Given this list of marker genes CSNK2A1, PARD6G, POLR1B, SPSB1, TAF11L13, WDR26, ANAPC2, CCNT2, LAS1L, KLHDC1, NFS1, ZC3H13, SPOP, POTEE, BARD1, TCEA1, CUL7, FEM1B, POLD1, POLR2L, ERCC8, PHF1, PKLR, TRIM21, ACVR2A, PFKP, ZZZ3, BABAM2, PRAMEF25, GTF2H3 (general transcription factor IIH subunit 3), ASB9, CDK5, ZYG11B, MED10, OSGEP, DPM2, TBP, POLR2J3, ASB1 (ankyrin repeat and SOCS box containing 1), CUL2, SPSB3, RCHY1, THUMPD3, RNF144B, RBM15B, HDAC9, WDR5, POLR1D, WDR4, TAF2, TBKBP1, ANAPC7, PAXIP1, UBE4A, SOCS7, CCNB3, ACACB, KDM6B, SKP1, UBE2J2, POLR2K, BCCIP, RABGGTB, KBTBD7, SNRPF, ZSWIM8, TBK1, RICTOR (RPTOR independent companion of MTOR complex 2), OST4 (oligosaccharyltransferase complex subunit 4, non-catalytic, NCBI Gene Id 100128731), NAA25, ATG13, UTY, PAGR1, EP300, HADHB, POLR2H, RPAP1, POLR2G, KBTBD8, FEM1A, TNFAIP1, SNRPE, CCNE1, FBXL17, TRIM37 (NCBI Gene Id 4591), BRPF1, CDC23, SUGT1, POLD3, NAA50, CHD8, BECN1, OTULIN, PHKG2, NRBF2, SUPT20HL1, TBC1D5, HCFC2, BRD1, PRKAR1B, ENY2, PRIM1, KCTD2, FBXO39, MED21, JARID2, MED8, MKLN1, POTEJ, JADE3, UBAC1, FBXL4, ZDHHC9, IFIT5, SHARPIN, POLD4, CDK10, ACTB, ANAPC13, FBXW5, GAN, DCAF12L1, KLHL8, GON7, ATF2, WWP2, TP53RK, PHKG1, FBXO46, BTRC, PARD6B, ACVR1C, MED13, FBXO2 (F-box protein 2), KBTBD6, MAT2B, KLHL12, MAD2L2, CDK4, MEAF6, KLHL11, CAB39L, FBXO3, UBE2C, VAC14 (VAC14 component of PIKFYVE complex), POLR2M, DTL, KLHL23, PRDM4, CLNS1A, METTL4, DMAC2, ANAPC10, POLR1F, BRD8, GTF2E1, TUFT1, POLE2, LYRM4, NCCRP1 (NCCRP1, F-box associated domain containing), RPN2, FNTB, PIGY, DCAF6, PEX2, DBF4, TAF5, CDK2, ANAPC4, PRAMEF26, POLR2F (NCBI Gene Id 5435), TERC, ASB12, LRRC75A, FZR1, UGT3A2, STK11, KDM6A, PIGS, TRPC4AP, BRCA1, N6AMT1, XRCC6, STT3B, PIAS4, RUVBL2, CKS1B, FBXO10, ABAT, TREX1, UBE2V1, WDFY3, PRKN, CCNY, PRAMEF6, POLR2E, FBXW4, TAF11L14, CCNA1, ZSWIM4, CDK19, DCAF8L2, TAF11L9, DLD, KLHL6, IPP, SNRPD2, ACVR2B, DCAF10, KLHL40, STRADB, RNF14, MCM3, KAT14 (lysine acetyltransferase 14), SF3B3, KDM1A, STRADA, PRKAR2A, POLR1C, PRAMEF7, NSMCE4A, PRKAB2, TAF11L2, PDCD6, ERN1, MED6, ANAPC15, GOLGA7, FBXO11, FBXL5, MAEA, YEATS2, PRAMEF5, SUPT7L, POLR2J2 (RNA polymerase II subunit J2), UBE2B, TAF13, RANGAP1, ING4, POLE3, KAT2A, DCUN1D2, MSL1, AKAP14, CCNT1, KLHL10, PAF1, RIOK1, NAA11, RTF1, TRRAP, RB1CC1, SYVN1, CDK7, GOLGA7B, CDK5R2, GTF2E2, ANAPC11, PRKY, FBXL20, VIRMA, PSG9, CCNL1, NAA10, MOCS2, PAAF1, FXN, AMN1 (NCBI Gene Id 196394), TAF9B, SAMD11, KCTD13 (NCBI Gene Id 253980), PIGU (NCBI Gene Id 128869), DCAF15, TMEM258, PRIM2, NAA20, CBLL1, DAD1, GTF2H2, CCNJL, CRCP, MNAT1, MAT2A, BOD1L1 (NCBI Gene Id 57219), KLHL25, SUPT20H, RMND5B, CCIN, TAF11L11, USP33, DDB2, GMPPA, GTF2F2, PRAMEF33, PDSS1 (NCBI Gene Id 23590), MED1, FBXL2, FBXO9, TAF6, IKBKE, ELOB, KANSL2, PRAME, RNF19B, PRAMEF17, RANBP9, FUT6, PRPF31, FBXL15, RCOR1, STUB1, ORMDL1, DNMT3L, KLHL20, PDSS2, MED17, ATG101, PIK3R6, ZER1, DCAF12, PFKFB1, PRKAA2, KAT6B, F13B, TADA1, PRPS1L1, KMT2D, TAF3, KLHL22, KAT8, TANK (TRAF family member associated NFKB activator), MEN1, TAF11L6, RNF8, FBXO38, CDK3, FBXW7 (NCBI Gene Id 55294), GTF2A1, FBXL16, PRAMEF2, CTR9, CDC27 (cell division cycle 27), POLD2, IKBKB, RPTOR, ANKRD9, KLHL41, PRAMEF18, MSL3, GMPPB, PCGF6, ANAPC1, PIK3CA, COMMD1, GTPBP3, ARMC5, CDK11B, POLR3H, GTF2A1L, PIGC, MBTD1, PIK3R5, TRMT11, FBXW8, ULK1, FBXL12, CCNQ, GNPTG, ALG14, MORF4L1, PHKA1, POLR3GL, SPTLC2, PCGF1, TBPL1, TADA2A, FNTA, ASB11, SESN2, GID8, CCNK, PIGP, QTRT1, TRAF2, PRAMEF8, JADE1, UBE3D, TGFBR1, DPH1, PIK3CD, PRKAR2B, STT3A, CHRAC1, POLR1E, RNF144A, PIK3R3, PCGF3, PRKAR1A, KAT2B, NAA16, USP22, EID3, NCOA6, UBXN8 (NCBI Gene Id 7993), TRAF7, GTF2F1, GTF2B, SNW1, SPTSSA, POLR3B, PRIMPOL, FBXW11, BUB1B, MMS19 (NCBI Gene Id 64210), CKS2, POLR1H, POLRMT, MBIP, PCMTD1, SENP3, FBXL3, TAF10, ARMC8, FBH1, ANAPC5, CDK13, THG1L (tRNA-histidine guanylyltransferase 1 like), SPSB2, SUZ12, YPEL5, POLR3K, DHDDS, TUSC3, DYDC1, WTAP, DCAF12L2, BECN2, UBE2U, CDK16, UBE2V2, ING3 (inhibitor of growth family member 3), COP1, POLR3A, ACTL8, PRAMEF12, TRMT61B, ARIH1, CBX6, SPTLC1, KBTBD3, KANSL1L, KLHL5, DPY30, PRKAB1 (NCBI Gene Id 5564), PIGH, GTF2H2C_2, PHC1, PHF19, MCRS1, ATXN7, MED27, SETD1B, ING5, DAW1 (dynein assembly factor with WD repeats 1), FBXO21, RNMT, CCNH, ATG5, UGT3A1, BRPF3, RNF2, CTU1, C9orf72, KLHL38, MAGT1, SNRPB (NCBI Gene Id 6628), ARIH2, MARCHF6, CDC20, PRAMEF22, DCUN1D4, HSD17B10, PEF1, ERCC3, MSL2 (NCBI Gene Id 55167), SAMD7, PHKB (phosphorylase kinase regulatory subunit beta), POMT1, PRAMEF15 (PRAME family member 15), GTF2H5, POTEI, RAMAC, POLE4, RBCK1, RNF168, CDC26, TRAF3, TMEM183A, MYZAP, CBX8, CBX5, DAPK1, CUL4B, DBF4B, DDB1, PRAMEF19, CDK14, PCGF5, ABTB1, LEO1 (NCBI Gene Id 123169), POLR2A, KANSL1, ZSWIM5, PIK3CB, PIGQ (phosphatidylinositol glycan anchor biosynthesis class Q), MORF4L2, UBR2, SEL1L (SEL1L adaptor subunit of SYVN1 ubiquitin ligase), AZI2, USP47, PCNA, PHF20L1, REV3L (NCBI Gene Id 7807), HSD17B12, TRMT6, KLHL9, WDR5B, TAF9, PRKAG2, FBXO7 (F-box protein 7), BRCA2, ASB4, TAF4, PARD6A, KBTBD2, NSMCE1, EP400, FBXO31, UBE2N, SKIC8, SGF29, TENT2, CCND2, EED, TAF4B, FBXO4, RNF31, CUL4A, EZH2, OGT, KLHL21, PRAMEF20, SMC5, ELOC, ZYG11A (NCBI Gene Id 440590), MTOR, KLHDC3, PFKM, DCAF17, POTEKP, PCGF2, PRAMEF11, IGF1R, POLR2I, GID4, KLHL18, NUS1, AEBP2 (AE binding protein 2), FBXO32 (F-box protein 32), SMURF2, F13A1, THUMPD2, TAF6L, PRAMEF1, EPC2, PIGT, FBXL19, RBX1, KLHDC2, WDR82, FBXL14, POTEF, YEATS4, SNRPD3, SUPT20HL2, ACTL6A, RNF217, MGRN1, DEPDC5 (DEP domain containing 5, GATOR1 subcomplex subunit), PFKL, DPH2, FBXO48, TAF8, WDR38, TRMT112 (tRNA methyltransferase activator subunit 11-2), INO80C, HADHA, PRAMEF4, UBE2L3, CSNK2A3, CAB39, ASH2L, DCAF4, MGA, ERC1, TEX10, TAF11L10, PRAMEF10, PIGA, DET1, CUL5, ENC1, DDOST, KCTD10, RNF11, POLR3G, CDC73, ACTBL2, ATG14, TAF11L7, DCAF4L2, RBBP5, ZNF335, HCFC1, UBE4B, DDA1, FBXL13 (NCBI Gene Id 222235), CUL9, CCNE2, WDTC1, MEGF8, CDKN2D, IRS1, KLHDC10 (NCBI Gene Id 23008), PYDC1, ELOVL6, PRKCI, ATG12, KCTD5, MAT1A, GPR37, E2F6, TAF1, DCAF7, RB1, AMBRA1, UBR1, KLHL35, RANBP10, CDK6, PIGM, POLG, KLHL30, GLMN, TAF1L, TAF11L4, UBR3, RNF40, DCAF8, KLHL17, FBXO42, CCNG2, CDK9, RNF7, VPS72, TAF7, ALG13, FBXL6, PRKACA, EZH1, MAVS, PIK3R4, SNRPD1, TAF7L, TAF11L3, KEAP1, MSL3B, PRKAA1, MAP3K7, QTRT2, GTF2H4, SKP2, ATG16L2, FBXO6, IKBKG, CCND1, AMFR, OSTC, CHUK, TAF11L8, CCNA2, PRKACB, POLR2J, DCAF1, CBX2, PHKA2, CCNP, PARD3, MAP3K5, CCNB1, CCNI (NCBI Gene Id 10983), KCTD17, CCNG1, POLG2, RBM15, PRKACG, NAA35, SMC6, DR1, KANSL3, MTO1 (NCBI Gene Id 25821), PIK3CG, UBE2E1, TAF11, NEDD4, PRKX, CDK1, GTF2A2, DCAF16, GPAA1, DCAF8L1, CCNO, TRMT61A, EPOP, EPC1, DCAF5, PRMT5, HDAC2, KMT2B, AKAP4, NDUFAB1, DCAF13 (DDB1 and CUL4 associated factor 13), KAT6A, CDK12, TAF5L, DCUN1D1, FAM8A1, XRCC5, ACTG1, FEM1C, KMT2C, CBX7, CDC20B, NAA38, TAF12, MED7, POLR3E (NCBI Gene Id 55718), DCUN1D3, DPM3, POLR1G, NAA15, KLHL1, CDKN1B, METTL14, DYDC2, TADA2B, RNF20, RANBP2, ORMDL2, PIGK, FBXO44, ANKIB1, KLHL42, KLHL24, DCAF11 (DDB1 and CUL4 associated factor 11), SPOPL, SUPT3H, RBBP7, KLHL15, NSMCE2, MED30, PRKCZ, TOPORS, UBE2S, KAT7, PHC2, POLR2C, RPN1, CCNC, BMI1, ACVR1B, TADA3, CBX4, SOCS2, TMEM183BP, ACVR1, TRIM40 (tripartite motif containing 40), SNRPG, LMO7 (NCBI Gene Id 4008), CDKN1A, PRPS1, DMAP1, FBXO8, POLA1, DCAF4L1, RING1, SLF2, RBBP4, BOD1, TPRKB, DCUN1D5, OS9, MIB2, RAD18, ACTL6B, POLA2, CSNK2B, MLST8, PHF20 (NCBI Gene Id 80330), INSRR, FBXL21P, PRAMEF13, PRAMEF9, CHML, KLHL4 (NCBI Gene Id 56062), PRKAG1, ASB2 (ankyrin repeat and SOCS box containing 2), KLHL2, CDK8 (NCBI Gene Id 1024), KLHL7, ERH, PRAMEF27, RNF19A, BRCC3, PRKAG3, CCNJ, FBXO27, MED31, FBXO17, NSMCE3, CUL1, POLR1A, MAX, PGGT1B, ZSWIM6, SMCR8, ATXN7L3, POLR2B, MTF2, NAA30 (NCBI Gene Id 122830), BRAP (BRCA1 associated protein), CDK11A, METTL1, CHM, HERPUD1, UBE2I, MAPKAP1, CNPPD1, INSR, DPM1, PIK3R2, SPTLC3, CSNK2A2, WWP1, DNA2, BCOR (NCBI Gene Id 57686), NEK10, SPTSSB, MLEC, SPSB4, SUMO4, CUL3, UVRAG, SIRT1, SETD1A, PRAMEF14 (PRAME family member 14), LAGE3, RUVBL1, SLF1, UBE2A, CCNF, MED11, PYCARD, CXXC1, KBTBD12, EXT2, ORMDL3, ZNFX1, PHC3, MRGBP (NCBI Gene Id 55257), ZBTB7A, CDC16, WDR77, POLR3C, KMT2A, PRMT1, LZTR1, CAND1, PRKDC, KAT5, TERT, MED12 (mediator complex subunit 12), STING1, TAF11L12, ATG16L1, TGFBR2, GTF2H2C, CDK5R1, ERCC2, RAD51, KRTCAP2, KLHL13, UBE2J1, IVNS1ABP, APPBP2, KLHL3, PELP1, FBXO24, KLHL29, FBXL7, RABGGTA, SF3B5, CRBN, C17orf49, FBXO15, CCNI2, JADE2, TRMT10C, METTL3, GTF2H1, RMND5A, PIGV (NCBI Gene Id 55650), POLE, FBXO45, CCNB2, CCND3, POLR3F (NCBI Gene Id 115527), POLR3D, CACYBP, ISCU, POLR2D, FBXO25, PIK3R1, PIK3C3, ATG3, DYRK2, ANAPC16, CREBBP, CCNL2, ILVBL (ilvB acetolactate synthase like), KLHL28, here is a description of the gene set: A protein complex capable of catalyzing the transfer of a group, e.g. a methyl group, glycosyl group, acyl group, phosphorus-containing, or other groups, from one compound (generally regarded as the donor) to another compound (generally regarded as the acceptor). Human Gene Set: GOCC_TRANSFERASE_COMPLEX species: Homo sapiens